The following is a description of a gene set: from publication Rhein P, Scheid S, Ratei R, Hagemeier C, Seeger K, Kirschner-Schwabe R, Moericke A, Schrappe M, Spang R, Ludwig WD, Karawajew L (PMID 17330098) Genes up-regulated in ALL (acute lymphoblastic leukemia) blasts after 1 week of treatment with glucocorticoids. Human Gene Set: RHEIN_ALL_GLUCOCORTICOID_THERAPY_UP In childhood acute lymphoblastic leukemia (ALL), persistence of leukemic blasts during therapy is of crucial prognostic significance. In the present study, we address molecular and cell biologic features of blasts persisting after 1 week of induction glucocorticoid therapy. Genome-wide gene expression analysis of leukemic samples from precursor B-cell ALL patients (n=18) identified a set of genes differentially expressed in blasts at diagnosis day 0 (d0) and persisting on day 8 (d8). Expression changes indicate a shift towards mature B cells, inhibition of cell cycling and increased expression of adhesion (CD11b/ITGAM) and cytokine (CD119/IFNGR1) receptors. A direct comparison with normal B cells, which are largely therapy resistant, confirmed the differentiation shift at the mRNA (n=10) and protein (n=109) levels. Flow cytometric analysis in independent cohorts of patients confirmed both a decreased proliferative activity (n=13) and the upregulation of CD11b and CD119 (n=29) in d8 blasts. The differentiation shift and low proliferative activity in d8 blasts may account for the persistence of blasts during therapy and affect their sensitivity to further therapeutic treatment. CD11b and CD119 are potential specific markers for d8 blast persistence and detection of minimal residual disease, which warrant further investigation. species: Homo sapiens, and this is the list of marker genes: BIRC3, GPR18 (NCBI Gene Id 2841), IQSEC1, MFN1, GLIPR1, MAX, S100A8, DUSP4, ANKRD11, DIDO1, SLC7A5, DEFA1, GABPB1-IT1, CHPT1, TCF25, MS4A1, CA1 (carbonic anhydrase 1), FOSL2, USP36, ASAH1, KLF9, DEFA4, ZNF331, P2RY10, LTF, GRK5, CEBPB, P2RX5, PTPRC, IFNGR1, CXCL8, LY86, MAP3K8, GABARAPL1, C15orf39, CD55, CYTIP, RGS13, PELI1, AHNAK, GTPBP1, ADAM28, CH25H, G0S2, DDX17, GPR65, DUSP5, EZR, IL1R2, TXNIP, NOTCH2, IDS, VNN2, KLHL2 (kelch like family member 2), ZNF571, CREM, RGS2, MNDA, ALAS2, LYZ, MIR22HG, ABCA1, ITGAM, ITPR3 (inositol 1,4,5-trisphosphate receptor type 3), DDX39B, NR4A2, SEL1L3, LY96, CRYBG1, GPR183, IL13RA1, ZNF165, AREG, SWAP70, CSTA, GLUL (glutamate-ammonia ligase)